The following is a description of a gene set: Base excision repair is initiated by DNA glycosylases that hydrolytically cleave the base-deoxyribose glycosyl bond of a damaged nucleotide residue, releasing the damaged base. Reactome Pathway: Base-Excision Repair, AP Site Formation part of: Base Excision Repair studied in species Homo sapiens, and this is the list of marker genes: H2BC5, H2AX, H3-4, H2BC12, NEIL1, H2BC13, H2BC9 (NCBI Gene Id 8345), H2BC4, H2BC17, NEIL3, TDG, H2AC18, H2BC14, H2AC6, SMUG1, H2AC4 (NCBI Gene Id 8335), H2AC14, H2AZ2, H2AC7, H2BC11, MUTYH, H2BC3, H2AJ, TERF2, ACD, NEIL2, H2BC1, H2BC12L, H2BC26, OGG1, H2AC20, NTHL1, H4C1, TINF2, H2AB1, TERF2IP (NCBI Gene Id 54386), H2BC15, POT1, UNG, MPG, MBD4, H2BC21, TERF1